The following is a description of a gene set: studied in species Homo sapiens Human Gene Set: HP_SENSORY_AXONAL_NEUROPATHY Sensory axonal neuropathy An axonal neuropathy of peripheral sensory nerves., and this is the list of marker genes: KLC2, SYNE1, NEUROG1, SAMD9L (NCBI Gene Id 4827), GAN, FXN, CCT5, PIEZO2, AIFM1, HINT1, SHMT2, ATP13A2, VRK1, VCP, NEFH, PLEKHG4, ACOX1 (NCBI Gene Id 8308), PRICKLE1, MFN2, CTSD, MORC2, ATL3, DHX16, DGUOK, XRCC4, TWNK, CAPN1, LMNA, TK2, HNRNPA1, PLD3, PTRHD1, OPA1, HNRNPA2B1, FGF14, POLG, GJC2, COX20, HEXB